The following is a description of a gene set: Mouse Gene Set: GOBP_HEMATOPOIETIC_STEM_CELL_MIGRATION studied in species Mus musculus The orderly movement of a hematopoietic stem cell from one site to another. A hematopoietic stem cell is a cell from which all cells of the lymphoid and myeloid lineages develop, including blood cells and cells of the immune system., and this is the list of marker genes: Ccr2, Kit, Jam2, Jam3, Bcl11b, Ext1, Ptprc, Mtch2, Cxcr4, Gas6, Enpp1